Given this list of marker genes KMT2B (NCBI Gene Id 9757), TBCE, SPG11, NAA60, PODXL, FTL, SYNJ1, ATP13A2, ALDH18A1, SPTLC1, DNAJC6, FA2H, ALS2 (alsin Rho guanine nucleotide exchange factor ALS2), UBA1, SIGMAR1, FUS, here is a description of the gene set: studied in species Homo sapiens Human Gene Set: HP_ANARTHRIA A defect in the motor ability that enables speech. Anarthria